The following is a description of a gene set: The process whose specific outcome is the progression of a sympathetic ganglion over time, from its formation to the mature structure. Human Gene Set: GOBP_SYMPATHETIC_GANGLION_DEVELOPMENT species: Homo sapiens, and this is the list of marker genes: SEMA3F, ASCL1, SEMA3A, INSM1, NRP1, PHOX2B, NRP2, CTNNB1, FZD3